Given this list of marker genes SWAP70, RAB3IP, HLA-DOB, PTDSS1, BTBD17, ERI2, LMBRD1, TMEM9B, FCRL1, LRRK2, OSBPL9, GGT1, CCND1, BICDL1, KRT84 (NCBI Gene Id 3890), YWHAE, SKI, IVD, SPIB (Spi-B transcription factor), TLR7, ASB5, GFRA1, DOK3, CAST, SPHK2, CDC5L, MAPKAP1, DYNC1H1, CNPY3, ANGEL1, DTX1, APOE, NEDD4L, CD79B, AP2A2, AMPD3, METTL3, XRCC1, INTS4, CERK, TUSC2, RPL6, FCRLA, PPP6R3, MLX, PRKD2, ZNFX1, CREBZF, ATF7 (activating transcription factor 7), PIAS3, PPBP, TSC22D1 (TSC22 domain family member 1), RNASE2, SLA2, CTDSP1, TRIOBP, ZBTB7B, MS4A1, LYN, PPP3CA, TTC28, HAAO (3-hydroxyanthranilate 3,4-dioxygenase), MED7, OASL, BLNK, FAM13C, SEC24B, CHRNA3, KLHL21, PRKD3, ZNF142 (zinc finger protein 142), GTF2H3, ITK, SENP6, CCDC127, DSC2, TES, RB1CC1, IQSEC1, DAG1, CR2, STAT6, THEMIS2 (NCBI Gene Id 9473), IGF2R, HLA-DMB, ACP5, EXOC8, PUS7, CD79A, AKT3, IL4I1, CNN3 (calponin 3), ZNF467, CARM1, RBM15B, LRRC23, AXIN1, RAD23A, STX1A, BLK, WWP1, IPO11, KLHL7, TDRP, ATP1B1, GUCA1B, RNF32, ALDH9A1, SORCS2, RAB3D, METTL13, RIPOR1, HLA-DRB1, ETNK1, PTK6, SRPK3, CYP39A1, MEF2C, CD74, SUSD6 (sushi domain containing 6), ANKS1A, AKIRIN1, ZFAND3, MYCBP2, DHX38, KDM4C, ANKRD40, PDCD2L, CHRNA4 (cholinergic receptor nicotinic alpha 4 subunit), SETDB1, PRPF8, VIP, CITED4, IPO4, BYSL (bystin like), RIPOR2, SCD, PTCRA, HS2ST1, PYGO2, APPL2, SCAF8, ADRB2, ACSS2, CAB39L, PCDH10, PDLIM1, PRPSAP2, CNNM3, GALNT10, IL1B, CSTF1, ACVR1B, MAP3K14, KCTD5, NANOG, TLE1, SPG11, CHPF, FLNA, CBX4, MAPRE1, CHST1, FGD2, IFNGR2, EIF2AK3, IL7R, PANX1, SBF2 (NCBI Gene Id 81846), DCP1A, ADD3, SSBP3, GPR63, VPS18, PADI2, UBTF, STIP1, PYCR1, TESK1, AVL9, HOXD9, TEX264, LSP1, DNAJB2, CIITA, ADM, NUMB, MTMR4, MYO18A, ACTN1 (NCBI Gene Id 87), CNGA1, SLC37A1, SFMBT2, MYO1H, PTPN6, DHX40, MCMBP, ADD1, HSPD1, GGA2, here is a description of the gene set: studied in species Homo sapiens from publication Layland LE, Mages J, Loddenkemper C, Hoerauf A, Wagner H, Lang R, da Costa CU (PMID 20007528) Human Gene Set: GSE17580_UNINFECTED_VS_S_MANSONI_INF_TEFF_UP Although several markers have been associated with the characterization of regulatory T cells (Treg) and their function, no studies have investigated the dynamics of their phenotype during infection. Since the necessity of Treg to control immunopathology has been demonstrated, we used the chronic helminth infection model S. mansoni to address the impact on the Treg gene repertoire. Before gene expression profiling we first chose to study the localization and antigen-specific suppressive nature of classically defined Treg during infection. Presence of Foxp3+ cells were found especially in the periphery of granulomas and isolated CD4+CD25hiFoxp3+ Treg from infected mice blocked IFN-gamma and IL-10 cytokine secretion from infected CD4+CD25- effector T cells (Teff). Furthermore the gene expression patterns of Treg and Teff showed that in total genes were significantly regulated during chronic schistosomiasis. Upon k-means clustering we identified genes exclusively regulated in all four populations including Foxp3, CD103, GITR, OX40 and CTLA-4: classical Treg markers. During infection however, several non-classical genes were up-regulated solely within the Treg population such as Slpi, Gzmb, Mt1, Fabp5, Nfil3, Socs2, Gpr177 and Klrg1. Using RT-PCR we confirmed aspects of the microarray data and in addition showed that the expression profile of Treg from S. mansoni-infected mice is simultaneously unique and comparative with Treg derived from other infections Genes up-regulated in comparison of T effector cells from uninfected mice versus T effector cells from mice infected with S. mansoni.